Given this list of marker genes CDCA8, CBX1, SOX30, MBD6, INCENP, SALL1, PIWIL2, TINF2, AURKB, MBD5, ESCO2, OIP5, CBX5, FMR1, here is a description of the gene set: species: Homo sapiens Human Gene Set: GOCC_CHROMOCENTER A region in which centric, heterochromatic portions from more than one chromosomes form a compact structure.